Given this list of marker genes CDX2, DMRT2, DLL1, NOTCH1, CDX1, LFNG, here is a description of the gene set: Any process that modulates the frequency, rate or extent of somitogenesis. Human Gene Set: GOBP_REGULATION_OF_SOMITOGENESIS studied in species Homo sapiens